Given this list of marker genes GAMT, SPINK1, CA2 (carbonic anhydrase 2), MT-TK, LRP5, CEACAM6, SLC37A4 (solute carrier family 37 member 4), TNFRSF13C, CEP19 (centrosomal protein 19, NCBI Gene Id 84984), NBAS, TREH, MANBA, CBL, RPGRIP1L, ADAR, IDUA, DEF6 (DEF6 guanine nucleotide exchange factor), FAM20C, SIK3, ALG11, HACD1, MMACHC, VCP, IDS, CP, MOCS2, BPGM, BCL2, POLG2, AKR1D1, MCM6, ERCC4, NPC2, DDC, TRIM32 (tripartite motif containing 32), RNASEH2A, SEC63, PIGF, PIGH, CEBPE, TYMP, MGAT2, PSMB9, BBS12, FBP1, PIGU, BRCA1, MT-TW, DPYD, LMBRD1, DNAJC19, SLC2A1, SMPD1, COLQ, UGT1A1, LAMB2, HLCS (NCBI Gene Id 3141), SERPINA1, GSR, NPC1, MT-ND4, RPS14, STX11, GNPTAB, MTM1, PEX2, SLC25A15, IFT172, RPS27, ALDH6A1, BBS10, VIPAS39, BCL6, PRKCSH, SLC25A4, OCRL, DHFR, SRSF2, CASR, JAG1, MYCN, HADHB, HNRNPA2B1, CYBA, AHCY, RINT1, SLC22A5, INSR, MLYCD, NAGS, MICOS13, CNOT1, GFM2, WARS2, NAGLU, TRAPPC11, RRM2B, TMEM38B, SDCCAG8, KY, CYP27B1, IFT56, ASXL1, ATP6AP1, GNE, PIGC, LRPPRC (NCBI Gene Id 10303), CLPB, ERCC8, BBS7, LIN28B, MTTP, MT-ND6, NR1H4, STAB1, ALK, STX5, HFE, GCLC, PHOX2B, PEX13, CYB5R3, TMEM67, GATA1, STEAP3, KIAA0586, XK, MT-ATP6, ABCD1, RB1, PGAP2, MRPS16, ACADVL, TNFSF12, TANGO2, CPN1, POLD1, PLOD1, IFT27, IRF2BP2, POLG, RPL35, MOCS1, ACACA, RPS7, SLC51A, SLC30A10, PIGS, RPL15, GATM (glycine amidinotransferase), DCDC2, POMT1, GLYCTK, FBXL4, KIF23, DMD, FKRP, CFTR, TMEM165, FXN, ADK (NCBI Gene Id 132), PSMB8, SERPINF1, NGLY1, NCF1, ACVR1, CYP2R1, ALDH5A1, HNF4A, MT-ND5, MST1, ABCG5, ARSA, CHEK2, ARSB, GPI, RUNX1, PIGW, BCAT2, STX1A, HADHA, F5, VPS33B, STOX1, B4GALT1, CEP290, SECISBP2, GALM, PHKA2, HEXB, FARSB, OPLAH, TMEM199, PLEKHM1, MT-ND2, RPS19, NEU1, CD81, UMPS, KLF1, AP1S3, STIM1, TNFRSF13B, GPD1, SH2B1, ASAH1, NFS1, LCT, HLA-DQA1, DDOST, COX5A (cytochrome c oxidase subunit 5A), XDH, GYS2, ALDOB, CTNS, RPL11, CRPPA, LYN, SQSTM1, ALDH4A1, MTHFD1, PIK3CG, IL36RN, ZNF687, FOCAD (NCBI Gene Id 54914), TP53, DLD, RHD, POU2AF1, DPM2, BCKDHA, MT-ND3, WRN, TKFC (triokinase and FMN cyclase), LDHB, COG8, DHDDS, TSR2, NPR2, BBS2, IBA57, SC5D, LPIN1, AIFM1, MMAA, APRT, SAR1B, GPAA1, ERCC6, HNF1B, BSCL2, GNPTG, SLCO1B3, CAT, ATRX, GALT, FLI1, CBS, PIGT, SCLT1, PGAP3, BICRA, RACGAP1, HPD, ARL6, LCAT, BBS5, RAG2, UROS, EDNRA, VPS13A, MYH9 (myosin heavy chain 9), COG5, ALDH2, NCF2, SBDS, PIGB, ABCD4, CALR, DPM1, PHYH, UBR1, ICOS, YARS2, ALG2, SLC6A14, CCDC47, CSPP1, ANKH, HSD17B4, ARSL, PYGM, ZNFX1, DNAJC21, LIG3, OBSCN, CAV3, HNRNPA1, ATP7B, OXCT1, SLC19A1, HADH, ABCC6, MT-CO1, COG4, PIGA, APOE, LARGE1, CR2, CLDN16, DLAT, CC2D2A, GIMAP5, SDHD, CYBB, TFAM, LIPT1, HSPG2, CD46, PEX19, MLIP (NCBI Gene Id 90523), SLC4A1, FARSA, FOXP3, MCCC1, CPA1, PRIM1, PHKB, PCCB, COQ4, HSD17B10, MPL (MPL proto-oncogene, thrombopoietin receptor), MARS1, CYP27A1, IFIH1, DYM, ABCG8 (ATP binding cassette subfamily G member 8), CLCA4, LIAS, MT-TV, GCDH, BOLA3, NSMCE2, CEACAM3, TNFRSF11B, HSD3B7, B4GAT1, MIF, DCTN4 (dynactin subunit 4), COG2, BBS9, NPHP1, AGXT, OTC, RPL27, MBTPS1, SLCO1B1, DPYS, HBB, RPS29, HJV, C18orf32, FH, APOA1, RPS26, COL4A1, NADK2, PLA2G6, CDKN2A, HK1, HLA-DQB1, SIL1, USP18, VDR, SMAD4, SUOX, UROD, PYGL, PRF1, TCIRG1, PIGG, ABCB4 (ATP binding cassette subfamily B member 4), STXBP2, RNF220, NT5C3A, GGCX, ADA, FADD, POMGNT1, GK, GAA, ANO10, GNMT, SGSH, IRF5, POMGNT2, EARS2 (glutamyl-tRNA synthetase 2, mitochondrial), GDF2 (growth differentiation factor 2), MPDU1, LBR, SLC25A13, RPS20, FAN1, PRSS1, PIEZO1, TNFSF15, DOCK2, FGF23, DAG1, SLC39A4, TRMU, KHK, NFKB2, PHGDH, ATP6AP2, GALC, TREX1, PIGY, MED12, SLC2A2, CD19, SP110, HAMP, MRPS2, TFR2 (transferrin receptor 2), EIF2AK3, SEC23B, NPR3, SCAPER, BCS1L, STAT2 (signal transducer and activator of transcription 2), PKD2 (NCBI Gene Id 5311), LZTFL1, SGMS2, MPI, APOB, PHEX, SPIB, SAMHD1, IFT74, PAH, RBCK1, RRAGC, DMGDH, LARS1, WDR35, TGFB1, SLC11A1, HIBCH, UNC13D, GNS, SPR, RPS15A, LIPA, MRPS28, FLT1, BBS4, ACSF3, PRSS2, RPS10, MOGS, QDPR, ENO3, PSMB4, PCK1, BMP2, MMADHC, SOST (sclerostin), OFD1, AMPD1, SCO1, SPP1, MPV17, GPHN, C1QBP, TTC8, COG6, FECH, RPS24, MT-ND1, ITPA, PANK2, PIGO, RABL3, TNPO3, TPP1, ALG3, PFKM, RNU7-1, PEX14, ALG12, NAGA, SLC9A3, CHST3, CTSA, NOS3, SUCLG1, BAAT, RPL5, ABHD5, PIGQ, IL12A, FUCA1, GALE, TOMM7, MTX2, BBS1, PKHD1, MRPL44, KIF12, GSS, HAGH, IRAK1, HMGCL, PRPS1, CFH, DPM3, ACADM, COG7, CYP7B1, SRD5A3, PALB2, GSTM3, MCCC2, SLC35A2, HMOX1, PEPD, PNPLA2, JAK2, RAG1, GUSB, RHCE, ACAT1, HMGCR, FTCD, ATP8B1, RRM1, MTR, RPL9, DGUOK (NCBI Gene Id 1716), MPO, MMAB, ENPP1, KIT, RHAG, GPR35, PITRM1, TRPS1, SEMA7A, PMM2 (NCBI Gene Id 5373), RNASEH2B, SUGCT, ALPL, PPOX, SLC4A2, DBH, RPL26, AGPAT2, LMO1, USB1, PKLR, CLCN7, CYC1, CFI, ARG1, PHKG2, PCYT1A, UQCRC2, MKS1 (NCBI Gene Id 54903), FKBP10, ABCD3, IARS1, BRCA2, HACE1, HEATR3, SLC34A1, ESR1, MT-TL1, RPS17, AMACR, ALAS2, POMT2, ASPA, CAVIN1, LIPT2 (lipoyl(octanoyl) transferase 2), AP1B1, RXYLT1, RPL18, INPP5E (NCBI Gene Id 56623), LYRM4, IVD, RPL35A, NSUN2, HYAL1, RNASEH2C, ASS1, PCCA, UPB1, GLB1, MICU1, MS4A1, IL18BP (interleukin 18 binding protein), GLRX5, SI, PPT1, ACOX2, GRHPR, MYC, PSAP, USP53, PRKCD, ALG6, SLC34A3, CYP3A4, SAT1, ABL1, SLC51B, TET2, VPS50, LSM11, ALAD, TNFRSF11A, CTRC, PEX16, KRAS, IER3IP1, CSF3R, CBLIF, DZIP1L, DMP1, GALNT3 (NCBI Gene Id 2591), ALMS1, MAN2B1, HLA-DRB1, RPL31, MMEL1, GBA1, PTH1R, CPT1A, TEFM, DPAGT1, WDPCP, IKZF1, TWNK, LYST, HLA-B, BCAP31, AGA, ACOX1, OTUD5, COX16 (cytochrome c oxidase assembly factor COX16), BTD, SLC7A7, PIGK, GNPNAT1, SRP54, G6PC1, EFL1, ELMO2, LRRK1 (NCBI Gene Id 79705), CORIN, OCLN, AUH, RPL8, CPT2, PIGL, DOLK, ADA2 (NCBI Gene Id 51816), NFKB1, AK1, ALDOA, PALLD, BGN, PLA2G7 (phospholipase A2 group VII), B3GALNT2, MYO5B, AGL, POMK, OGDH, LMNA, SCARB2, SEMA4D (semaphorin 4D), PGM1, GLA, ACSL5, FKTN, MT-CO3, CDAN1 (NCBI Gene Id 979), TCF4, PHKG1, GGT1, ATM, FHL1, STAT4, KCNN4 (NCBI Gene Id 3783), HMBS, UQCRB, BCHE, AASS, SLC25A20, PEX7, GNPAT, CEP164, ABCB11, CFAP418, FAH, HELLPAR, SLC26A9, PIGV, MTHFR, TRPV6, TRMT10C, TULP3, PRDX1, ASL, ALDH3A2, MRPL3, LHX1, IL12RB1, ALG8, GALK1, SPTBN1 (NCBI Gene Id 91654), AGPS, PLEC, MTRR, MVK, ACAD9, PHKA1, LDHA, BCR, HMGCS2, CCDC115, MKKS, FCSK, BBIP1, RPS28, here is a description of the gene set: Abnormal enzyme concentration or activity species: Homo sapiens Human Gene Set: HP_ABNORMAL_ENZYME_CONCENTRATION_OR_ACTIVITY Concentration or activity of an enzyme is above or below the limits of normal.